Given this list of marker genes Parp1, Trex1, Parp2, Cyp1b1, Exosc5, Exosc6, Dntt, Aicda, Apobec3, Cdadc1, Exosc4, Exosc3, Apobec1, Parp3, Gstt1, here is a description of the gene set: Mouse Gene Set: GOBP_DNA_MODIFICATION studied in species Mus musculus The covalent alteration of one or more nucleotide sites in DNA, resulting in a change in its properties.